The following is a description of a gene set: studied in species Mus musculus Mouse Gene Set: ZFP661_TARGET_GENES Genes containing one or more binding sites for (Zfp661) in their promoter regions (TSS -1000,+100 bp) as identified by GTRD version 20.06 ChIP-seq harmonization. from publication Yevshin I, Sharipov R, Kolmykov S, Kondrakhin Y, Kolpakov F (PMID 30445619), and this is the list of marker genes: Adck5, Tia1, Mirlet7g, Rgcc, Ebf2, Shroom3, Gm10941, H3f3a, Arhgap18, C130074G19Rik, Gm23838, Irak2, Tmem242, Gm7094, Gm11999, Ackr3, Nceh1, Kdm3b, Zbtb17, Rhou, Dpep3, Nsfl1c, Phospho2, Immt, Nus1, Wwtr1, Exph5 (NCBI Gene Id 330943), Zfp644, Pear1, Acaca, D5Ertd605e, Tjp2, Chd1, Hnrnpm, Endov, Pcdhga2, Pcdhga9 (NCBI Gene Id 93717), Mast4, Polrmt, Pcdhb3, Itga9, 2610005L07Rik, Cenpb, Psmd3, Gm5444, Otos, Racgap1, Trps1, Fgf6, Ephb6, 4930558K02Rik, Gm5432, Nrtn, Btbd3, Pxylp1, Snx1, Robo3, Ddah1, Arrdc3, Gm38293, Npdc1, Plekhg4, 1110002E22Rik (NCBI Gene Id 99617), Ston1, Ssc4d, Eef2k, Upf3a, Arhgap31, Tcf7l1, Marchf11, Cflar, Gssos2, Cfap100, Fxr2, Hectd3, Platr26, Mis18bp1, St8sia3, Crot, Samhd1, Cds2 (NCBI Gene Id 99122), Cd37, Mbd3 (NCBI Gene Id 17192), Sult6b1, Spock2, Prep, Dglucy, Fbxo46, Rpl13a (ribosomal protein L13A), Fam83g, Acin1, Cryzl1, Dhx32, Mob3b (MOB kinase activator 3B), Rapgef1, Gm16740, Kif1b, Exoc7, Cep85, Aloxe3 (NCBI Gene Id 23801), Setd3, Coro1a, Mrps10, Pam16, Krtcap3, Pou4f2, Rora, Smagp, Adamts3, Zfp37, Zfp667, 5430405H02Rik, Praf2, Rap1gds1, Rexo1, Lyrm1, Mest, Sec24a, Zfp598, Abitram, Slc7a7, Nob1, Akt2, Tex14, Fam124a, Tm7sf3, 4930539J05Rik, Rac3, Spmip4, Pnpla3, Drap1, Septin4, Tonsl, Mir671, Cpeb3, Fntb, Asf1a, Borcs5, Styk1, Drd1, 4930463O16Rik, Mrps27, Ccny, Mroh7, Calr, Cblc, Spmip7, Pnisr, Pfkfb3, Nrxn2, Kbtbd11, Ift70a1, Dgkz, Arhgef18, P2rx7, Garem2, Mtmr6, Tmbim6, Radil, Pcdhgb5, Abcf2, Wdr37, Nxt2, Dbil5, 1700122E12Rik, Rasgef1a, 1110038B12Rik, Gm9978, Dtnbp1, 2010109A12Rik, Ino80d, Chrnb2 (NCBI Gene Id 11444), Slc35e4, Epc2, Sdc4, Cep131, Ccnk, Ikzf1, Kif26a, Gm37885, Gtpbp4, Gm25268, Rab27a, Ednra, Map3k4, H2-M5, Sec62 (SEC62 homolog, preprotein translocation), Ptp4a2, Zfp763 (zinc finger protein 763), Csgalnact2, Pcdhac1 (protocadherin alpha subfamily C, 1), Cebpzos, Ermp1, Pofut2, Itsn1, Iscu, Tram1, Olig2, Ddias, Mir8120, Ltbp1, Mitd1 (MIT, microtubule interacting and transport, domain containing 1), Ppp6r1, Dag1, Gm13067, Pcdhga8, Entpd6, Trp53inp1, Grid2ip, Pcdhgb1 (protocadherin gamma subfamily B, 1), Ccdc50, Myo1b, Smpd4, Mdk, Camkk2, Ankhd1, Nsdhl, Ppfibp2, Syne1, Nudt17 (NCBI Gene Id 78373), Adamts17, Pard3 (NCBI Gene Id 93742), Dop1b, St3gal3, Snx11, Gm26253, Fxn, Bcl7c, Vstm5, Dnajc11, Chsy1, Srrm1, Wnt10a, Ing4, Chadl, Klf16, Zfp219, Shpk, Gm15941, Tuba1b, Gem, Aga, Stum, Gm9103, Satb1, Zfp637, Akap13, Npc1, Ing5, Rbm19 (RNA binding motif protein 19), Ripk1, Ino80dos, Mylpf, Idua, Pdlim7, Rab5if, Got1, Mycl, Klc2, Gm973, Alkbh7, Usp19, Pced1c-ps (PC-esterase domain containing 1C, pseudogene), Zfp68, Strbp, Abl2, Mepce, Rere, 2410021H03Rik, Epb41l4b, Pcdhgb8, S100a2, Kcnk13, Sptbn1, Coil, Adamts6, C630004M23Rik, Prss48, Prkag2, Neo1, Gm16599, Fam83d, Gm12446, P2rx2, Chchd4, Tppp, Stip1, Myo1h, Sh3bp5, Myo10, Alg5, Pms2, Tmem43, Ap1g1, Mrap2, Gm9385, Mrpl11, Pgbd5, BC064078, 1300002E11Rik, Pcdhga12 (protocadherin gamma subfamily A, 12), Stag1, Cystm1, Huwe1, Zfp420, Abcc10, Tcam1, Zmynd8, Pgk1 (phosphoglycerate kinase 1), Slitrk5, Zfp568, Mir6392, Galnt4, Hs3st4, Tspan4, Camta2, Lrrc36, Pcdhga5, Ap5s1, Qars1, Pcdhga11, Gm3364, Mir7675, Fam234b, Elk1, Cbll1, Pcdhga3, Chrdl2, Rgs17, Tpp2, Rpl36, Pdzd9, Sorcs2, Mast1, Gm53, Mthfsd, Acot1, Gm12235, Atox1, Crybg2, 3222401L13Rik, Rnf216, Akt1, Kdm1b (NCBI Gene Id 218214), Zc3h14, Adnp, Ralgapb, Rab23, Smim45, Mpzl2, Tent4a, Cic, Trpv2, Fut9, Gorasp2, 4930580E04Rik, Ngdn, Ctsf, Dcun1d3, Epb41l4a, Slc32a1, Zfp825 (NCBI Gene Id 235956), Limk1, Kcnh4, Fhdc1, Zdhhc5, Vwf, Cfap54, Rex1bd, Mien1, Pals2, Lsmem1, Gm19200, Rbpj, Pigc, Lgi4, Vipr2, Cdkn2c, Prob1, Ccdc13, Pdgfra, Vars1, Otub1, Abtb3, Zfp704, Pde5a, Fastk, Grip1, Mir8109, Arid2, Gm14101, Uvssa, Mbd1, Tbl1xr1, Lemd1, Dtl, Hmg20a, Mllt10, Gm18036, Dpysl3, Map3k5, Timm13, Fbxo7, Mapkap1, Ube2d3, Mpv17l2, Tsnax, Yipf3, Cetn2, Dnajc13, Mtf2, Zfp469, Mpo, Khk, Rbm17, Zfp532, Tmem63b, Mir7035, Notum, Ppard, 1700008O03Rik, Hgsnat, Rps2-ps9, Reps1, Mpped2, Fbxl3, Lrrc27, Mknk1, Nectin2, 4833407H14Rik, Resf1, Mir3965, St6galnac2, Tex9, Nptx2, Nap1l4, Tsc22d2, Gemin4, Csgalnact1, Slain1, Plch2, Cep120, Prmt3, C2cd3, Aars1, Ctcf, Gm3329, Gm28836, Nbn, Sp1, Rell2, Erbin, Tlr2, Snx18, Gm24432, Cmah, 1110002J07Rik, Rnf167, Dnm1, Yif1b, 1700063H04Rik, Usp18, Htr5a, Ldb1, Rab36, Wsb2, Gm15912 (predicted gene 15912), Gm26812, Hap1, Pax6, Nmt2, Tlr5, Trmu, Yipf5, Pcdhga7, Cnot7, Socs1, Fosl2, Hoxd10, Thumpd2, Azi2, Ptcd2, Pacsin2 (NCBI Gene Id 23970), Kptn, F3, Hscb, En2, Ctsh, Pmvk, Ccdc88c, Zfp346, Rest, Gm10143, Trbv12-1, Tcof1, Ywhag (NCBI Gene Id 52802), Col23a1, Zfp398, Chd2, Prlhr, Tnfrsf22, Cbfb, Pcdhgb4, Zbtb39, Zfp786, 4732491K20Rik, Scx, Glt8d2, Grb2, Uqcc5, Ccni, Ppme1, Kctd7 (potassium channel tetramerisation domain containing 7), Exosc8, Cnot10, Tppp3, Myo3a, Eif4e, Atf6b, Ppp1r9a, Matk, Clstn2, Nck1, Gabra5, Zcwpw2, Etl4, Dancr, Hcrtr1, Ctns, Tyro3, Pcdhgb6, Gm16271, Def8, Sh3bgrl2, Myrf, Zfp383, Get1 (guided entry of tail-anchored proteins factor 1), Tpmt, Rap1gap2, Tnfrsf19, Celrr, Usp46, Myo1d, Cldn1, Gstt2, Cast, Plec, Smg7, Rps6kc1, Ints1, Anxa7, Notumos, Atxn1l, Rps6ka1, Zfyve9, Chst7, Slc9a8, Gm10605, Coq2, H3f3b, Ablim1, Acbd4, Slc8b1, Tmcc1, Gm10535, Otud5, Camk1d, Rnls, Snapin, Park7, Slc12a9, Kctd1, Rasal1, Mbtps2, Wdr48, Tafa5, Mras, Vav3, Atg4c, Slc45a4, Zbtb6 (zinc finger and BTB domain containing 6), Crbn, Numb, Pcdhgb7, Sdk1, Aldh1a2, Zfp2, Gne, Prr36, Cacnb3, Cd46, Slc38a3, Oma1, Cyb561d1, Cask, Inpp5f, Filip1, Ypel5, Gm23592, Srl, Tdrd3, Wdsub1, Frg1, Mta3, Ubxn11, Sez6, Helb, Cuedc1, Acvr1, Pias3, Dgat1, Prdx1, Tpd52l1, Fbxo30, Col1a1, Gm16016, Rab32, Chaserr, Ly6k, Atg16l1, Snora26, Foxs1, Pds5a, Nasp, Rpl36a, Kansl1, 1700112K13Rik, Mtnr1a, Crk, Spns2, Fbxl2, Adra1b, Nt5m, Phf19, Gm24667, Gm10244, Ltb4r2, Pfdn4, Hlcs, Prcp, Syn3, Spats2l, Fuca1, Auts2, Zswim4, Ddx20, Qser1, Cgref1, Alkbh8, Gm16104, Hdac11, Fmo5, Polr3a, Celf5, Gm24631, C230035I16Rik, Ptpre, Tamm41, Tmtc1, Syndig1, Farp2, Stimate, Ckap5, Gm14285, Gatd1, Abraxas2, Chd8, Cln8, Nipbl, Eif4e2, Phactr3 (NCBI Gene Id 74189), Mir100hg, Mad2l2, Vsir, Nipsnap2, Fmc1, Adpgk, Slc39a13, Gm15883, Prss50, Ube2l6, Gm12035, Agtrap, Gm11532, Vps18, Tafa3, Lrrc3c, Kctd19, Ppwd1, Ngfr, Chrd, Phf24, Lima1, Tkt, Shroom1, Rbm39, C330002G04Rik, Hdac5, Rpl37, Aldh1l2, Rprd1a, Men1, Fam222b, Srpk1, Osbpl6, Rpl38, Pcdhga1, Ltbp4